Given this list of marker genes IER3IP1, DNM1L, SMCHD1 (NCBI Gene Id 2490), CUL4B, ERCC6, LHX4, AIRE (autoimmune regulator), TUBA1A, MRPS7, SOX2, DMPK, ELN, ANK1, ZFPM2, PNPLA6, UBE4B, BMP6, DDB2, DHH, NRAS, BRCA1, RRAS2, POU1F1, CBL, WDPCP, EIF4H, TERT, METTL27, SDCCAG8, TMEM270, MANF, KISS1R, ATRX, CYB5A, IFT172, CHRNG, DNAJC30, PEX1, TRIM32, MT-ND4, ATP5MK, MT-ND6, TP63, MKKS, ATP5F1E, SEMA3A, ABCD1, BMP4, ATPAF2, ARSL (NCBI Gene Id 415), SNORD116-1, HSPG2, MT-CO1, CASZ1, BBS7, CISD2, FANCF, FANCD2, BBIP1, TGFB1, FANCA, SEMA3E, ERCC2, MT-ATP8, RERE, FGF17, NUP107, MT-TH, LIG3, LZTR1, LHCGR, SGPL1, RAD51C, BAZ1B, BRAF (NCBI Gene Id 673), BRIP1 (NCBI Gene Id 83991), MT-TW, WRN, CTNS, PTCH1, SPRTN, TFR2, RAB3GAP2, MAGEL2 (NCBI Gene Id 54551), FANCB, ALG1, PMM2, FMR1, OPA1, PDGFB, POLG, MAD2L2, NF2, SLC29A3, TP53, ZBTB20, DHX37, CYP17A1, ATP5F1A, CLIP2, SLC30A7, CHD7 (NCBI Gene Id 780907), SPEN, NTN1, LHX3, KISS1, STS, KRAS, MDM2, NDNF, POLR3K, AMACR, SIL1, POLR1C, PALB2, MT-CO2, RRM2B, VPS4A, AR (androgen receptor), SPRY4, CEP19, BAP1, WT1, MYH3, MT-TS2 (mitochondrially encoded tRNA-Ser (AGU/C) 2), OCA2, FANCM (FA complementation group M), MKRN3, SLX4, MT-ND5, RASA2, BRCA2, NPHP1, HJV, NSMF, ATM, CCDC141, BRCC3, GLI2, KIF21A, MT-CO3, CCDC28B, CDKN1C, PHGDH, POLA1, RFWD3, GTF2IRD2, NECTIN1, NHLH2, ATP5F1D, ALMS1, ARL6, PRLR, FSHB, PWAR1, PCSK1, TYMP (NCBI Gene Id 4334), TRAF3IP1, BMPR1B, SMO, MEN1 (menin 1), AIP, RNF216, SNORD115-1, SNRPN, HSD17B3, TACR3, USP7, SOX10, PPM1B, TBL2, BUD23, BBS9, REV3L, MMP23B, FEZF1 (NCBI Gene Id 392779), GTF2IRD1, ERCC5, FANCL, ITGB6, RFC2, XPC, MT-TF, MKS1, ERCC3, GATA4, COL25A1, GALT, RBM28, DCC, WDR11, NDN, SIX6, WWOX, GNAS, PIK3CA, PRDM16, ERCC1 (NCBI Gene Id 2067), GALK1, SOX9, FGFR1, SKI, PROK2, UBE2T, MT-TL1, NPAP1, AKT1, HESX1, DCAF17 (NCBI Gene Id 80067), CLPP, RECQL4, FANCE, BBS2, CNBP, PRORP, ZMPSTE24, VAMP7, PEX6, NCF1, CTDP1, OTX2, AXL, BCS1L (NCBI Gene Id 7856), SQSTM1, PROKR2, SNAP29, TCF12, LSS, SCP2, KCNAB2, CEP290, CPE, MGME1, PRKCZ, SIM1, CAMKMT, ANOS1, SOS1, GNRH1, COQ2, CBX2, MECP2, RAF1, AHSG, MYT1L, DMRT1, SAMD9, FOXL2, EIF2S3, PTPN11, STEAP3, IFT27, MRE11, PHF6, POLE, FANCC, LMNA, PRDM13, BBS1, ERCC4, RNU4ATAC, SOS2, SLC3A1, RAB3GAP1, MAP2K1, RAD51, PWRN1, LZTFL1, GABRD, PHOX2A, HFE, STUB1 (STIP1 homology and U-box containing protein 1), MT-TQ, LIMK1, TUBB2B, ZFX, SRA1, PROP1, FANCI, TRAF7 (TNF receptor associated factor 7), HBB, SMAD4, GPR101, CTNNB1, FLRT3, NR0B1, WFS1, SMARCB1, SLC39A4, POLR3B, PTCH2, BBS4, BBS5, LGR4, PDE4D, VPS37D, IFT74, SPRED2, HAMP, FOXA2, MT-ATP6, FKBP6, XRCC2, IGF1, ALX4, RIN2, SOX3, XPA, RRAS, BBS10, DNAL4, HERC2, GJB2, CDH23, LHB, DUSP6, ANTXR1, CYP19A1, HS6ST1, TAC3 (tachykinin precursor 3), STX1A, PTDSS1, SUFU, BMP15, MAP3K1, PDPN, BMP2, GNRHR, CFAP418, ERCC8 (ERCC excision repair 8, CSA ubiquitin ligase complex subunit), MT-ND1, CHD4, RIT1, FANCG, LEP, SCAPER, DMXL2, POLD1, TUBB3, MRAS, FGF8, IL17RD, ANAPC1, TTC8, TWNK, LAS1L, SRY, POLR3A, NR5A1, SMARCE1, SCLT1, HDAC8, PRKAR1A, LEPR, LUZP1, BBS12, GTF2I, PLXND1, PREPL, here is a description of the gene set: species: Homo sapiens Hypogonadism Human Gene Set: HP_HYPOGONADISM A decreased functionality of the gonad.